Given this list of marker genes SURF4, SEC61B, AFG2B, TMEM30B, HSP90B1, OS9, UBE2J1, TECPR2, SEL1L, VCP, NPLOC4, TM9SF4, EDEM2, INSIG1, HERPUD1, GCC2, RANGRF, DERL1, CRYZL2P-SEC16B, CD81, SLC51B, FAF2, BCAP31, LMAN1, STEEP1, SEC13, SEC16A, SYVN1, SELENOS, SEC16B, TMEM129, EDEM1 (ER degradation enhancing alpha-mannosidase like protein 1), RHBDD1, TMEM30A, YOD1, DERL2, SVIP, MIA2, DERL3, HM13, AUP1, MAP1LC3C, UFD1, TMED9, UBE2G2 (ubiquitin conjugating enzyme E2 G2), UBAC2, ERLEC1, SLC35D3, BRSK2, SORL1 (NCBI Gene Id 6653), here is a description of the gene set: species: Homo sapiens The directed movement of proteins from the endoplasmic reticulum. Human Gene Set: GOBP_PROTEIN_EXIT_FROM_ENDOPLASMIC_RETICULUM